The following is a description of a gene set: Any process that stops, prevents, or reduces the frequency, rate or extent of chromosome segregation, the process in which genetic material, in the form of chromosomes, is organized and then physically separated and apportioned to two or more sets. species: Homo sapiens Human Gene Set: GOBP_NEGATIVE_REGULATION_OF_CHROMOSOME_SEGREGATION, and this is the list of marker genes: AURKB, MAD2L1, TTK, CDK5RAP2, TPR (translocated promoter region, nuclear basket protein), ATM, MAD1L1, HASPIN, BIRC5 (NCBI Gene Id 332), CENPF, PRP4K, XRCC3, SPC24, CHFR, ZWILCH, IK (NCBI Gene Id 3550), ZWINT, CDC20, DUSP1, SPC25, DYNC1LI1, USP44, FBXO5, ANAPC15, NDC80, BUB3, SIRT1, PSMG2 (NCBI Gene Id 56984), BUB1B, KNL1, PRAP1, TEX14, SPDL1, KLHL22, SKA3, MOS, RAD21, TRIP13, MAD2L2, LCMT1, CDCA8, KNTC1, PLK1, ZNF207, BUB1, ZW10, MAD2L1BP, NUF2, INCENP, SKA1, CCNB1, GEN1, APC